Given this list of marker genes Fdx2, Zbtb17, Ubiad1 (UbiA prenyltransferase domain containing 1), Zic4, Ppp3cb, Prpf40a, Ppp1cb, Macrod2, Igdcc3, Naa50, Cd40, Rilpl1, Wnt5b, Bst1, Slx4ip, Trip4, Tead1, Myef2, Slc17a3, Psd3, Nmrk2, Arih2, Enah, Ddx55, Arhgef26, Btg1, Rab26, Tbr1, Egfem1, Ankrd33b, Hoxb7, Dolpp1, Guca1b, Rnf169 (NCBI Gene Id 73007), Smad1, Zfp809, Ak2, Tcim, Rflna, Wdr18, Cd3e, Scai, Duxf4, Nr1h5, Cabp5, Adipor2, Glul, Ttc39b, Atxn1l, Pag1, Rfx4, Slc35f3, Btg1c, Ppp4r3a, Atg9a, Cyp2j13, here is a description of the gene set: Genes predicted to be targets of miRBase v22 microRNA mmu_miR_7239_5p in miRDB v6.0 with MirTarget v4 prediction scores > 80 (high confidence targets). Mouse Gene Set: MIR_7239_5P from publication Chen Y, Wang X (PMID 31504780) studied in species Mus musculus